The following is a description of a gene set: Human Gene Set: MIR3183 from publication Chen Y, Wang X (PMID 31504780) Genes predicted to be targets of miRBase v22 microRNA hsa-miR-3183 in miRDB v6.0 with MirTarget v4 prediction scores > 80 (high confidence targets). species: Homo sapiens, and this is the list of marker genes: CASZ1, CARMIL1, M6PR, GRIA3, ELFN2, NRXN1, ZSCAN31, IGF1, MANEA, MAP1A (NCBI Gene Id 4132), ZFYVE27, MYO5A, SPEG, TARS3, IGFBP5, SAE1, EHD3, HEG1, SMARCC2, UBE3D, AGAP1, NKAIN1, SFMBT1, TNFRSF13B, SPR, TMCC2, KSR2 (kinase suppressor of ras 2), PKHD1, LBX2, ZCCHC2, RXRA, AGFG2, APOBEC2, SLC25A30, SLC52A3, ZNF618, ING5, EPPIN-WFDC6, PITPNC1, FBXW11, GMEB2, LRCH4, GPATCH2L, CDH11, PCBP3, SERTAD4, CCNT1 (NCBI Gene Id 904), UBXN10, TVP23C, SCYL2, SETD3, PDE3B, ELF3, SPDYE5, NUP160, ABRAXAS2, ZBTB37 (NCBI Gene Id 84614), GABBR2, CNOT9, ZNF629, NMUR2, ZNF514, CHRNA1, CHD3, SPDYE3, LYN, TENM4, PHKA1, FAM168A, EYA2, SLC24A4, PTPN1, NR2F1, APOLD1, ZBTB7C, PLCB1, SMAP2, SPDYE1, LRP11, CCBE1, AADACL3, CSF1